The following is a description of a gene set: species: Homo sapiens Tortuous cerebral arteries Excessive bending, twisting, and winding of a cerebral artery. Human Gene Set: HP_TORTUOUS_CEREBRAL_ARTERIES, and this is the list of marker genes: SMAD3, COL5A1, ALDH18A1, RNU4-2, IPO8, APP